The following is a description of a gene set: Mouse Gene Set: GOBP_DENDRITIC_CELL_DIFFERENTIATION studied in species Mus musculus The process in which a precursor cell type acquires the specialized features of a dendritic cell. A dendritic cell is a leukocyte of dendritic lineage specialized in the uptake, processing, and transport of antigens to lymph nodes for the purpose of stimulating an immune response via T cell activation., and this is the list of marker genes: Ltbr, Gas6, Zbtb46, Cd40lg, Irf8, F2rl1, Lyn, H2-M3, Ubd, Trpm2, Dcstamp, Irf4, Itgb8, Slamf9, Pirb, Tnfsf9, Batf3, Gimap3, Itgb6, Ccl19, Ccr7, Gata1, Traf6, Tmem176a, Flt3l, Flt3, Batf2, Gimap5, Trem2, Hmgb1, Rbpj (recombination signal binding protein for immunoglobulin kappa J region), Relb, Tgfbr2, Axl, Cebpb, Azi2, Csf2, Clec12a, Tgfb1, Notch2, Batf, Camk4, Prtn3, Ager, Tmem176b, Psen1, Spi1, Il4